The following is a description of a gene set: This event has been computationally inferred from an event that has been demonstrated in another species.<p>The inference is based on the homology mapping from PANTHER. Briefly, reactions for which all involved PhysicalEntities (in input, output and catalyst) have a mapped orthologue/paralogue (for complexes at least 75% of components must have a mapping) are inferred to the other species. part of: Signaling by PTK6 species: Mus musculus Reactome Pathway: PTK6 Regulates RHO GTPases, RAS GTPase and MAP kinases electronically inferred by orthology from the curated human pathway, and this is the list of marker genes: Rasa1, Crk, Hras, Pxn, Bcar1